Given this list of marker genes Scgb1b27, Osbpl11, Npc2, Hsd3b1, Hsd17b10, Osbpl10, Paqr8, Cav1, Nfe2l1, Pgr, Paqr9, Stard3, Cyp11b1, Comp, Erlin2, Gstm1, Paqr5, Soat1 (NCBI Gene Id 98715), Cyp21a1, Ugt1a9, Slc38a9, Calb1, Osbp, Ninj2, Ugt1a8, Vdr, Vdac1, Tmem97, Bspry, Hsd17b1, Paqr6, Slc22a2, Rora, Paqr7, Cyp2r1, Insig2, Ugt1a7c, Smo, Star, Pgrmc2, Hsd11b2, Apod, Sult2b1, Esr2, Syp, Ar, Apoa2, Serpina6, Sult1e1, Stard4, Scgb1b7, Osbpl7, Scap, Scp2, Erlin1, Scgb1b24, Stard3nl, Ephx1, Gpr141 (NCBI Gene Id 353346), Insig1, Pdia2, Atp1a1, Osbpl8, Nr3c2, Prom1, Scgb1b12, Nr3c1, Hsd3b9, Crp, Scgb1b3, Pgrmc1, Scgb1b20, Osbpl3, Npc1l1, Cd81, Gper1 (G protein-coupled estrogen receptor 1), Stard5, Esrrb, Gramd1c, Nr1h4, Atp1a2, Esr1, Minar2, Gramd1b, Hsd11b1, Scarb2, Cyp11a1, Cyp3a13, Osbpl2, Scgb1b10 (NCBI Gene Id 102635992), Pmp2, Hsd3b4, Osbp2, Tspo2, Gc (vitamin D binding protein), Hsd3b5, Scgb1b2, Tmem199, Hsd3b8, Gas1, Npc1, Akr1c21, S100g, Ugt1a1, Sidt1, Osbpl9, Stard6, Atp5po (NCBI Gene Id 28080), Osbpl6, Osbpl5, Prom2, Osbpl1a, Vdac2, Gramd1a, Scgb1b30, Soat2, Gpr155, Rorc, Shbg, Gpr183, Igf1 (insulin-like growth factor 1), Scgb1b15, Scgb1b19, Ugt1a10, Esrrg, Esrra, Ptch1, Anxa6, Apoa1, here is a description of the gene set: studied in species Mus musculus Mouse Gene Set: GOMF_STEROID_BINDING Binding to a steroid, any of a large group of substances that have in common a ring system based on 1,2-cyclopentanoperhydrophenanthrene.